The following is a description of a gene set: Genes upregulated in Treg cells from Progressive Idiopathic Pulmonary Fibrosis Patients vs. Stable Non-Progressors from publication Unterman A, Zhao AY, Neumark N, Schupp JC, Ahangari F, Cosme C Jr, Sharma P, Flint J, Stein Y, Ryu C, Ishikawa G, Sumida TS, Gomez JL, Herazo-Maya JD, Dela Cruz CS, Herzog EL, Kaminski N (PMID 38717443) species: Homo sapiens Thirty-eight PBMC samples from 25 patients with IPF and 13 matched controls yielded 149,564 cells that segregated into 23 subpopulations. Classical monocytes were increased in progressive and stable IPF compared to controls (32.1%, 25.2%, 17.9%, respectively, p<0.05). Total lymphocytes were decreased in IPF vs controls, and in progressive vs stable IPF (52.6% vs 62.6%, p=0.035). Tregs were increased in progressive vs stable IPF (1.8% vs 1.1% of all PBMC, p=0.007), although not different than controls, and may be associated with decreased survival (P=0.009 in Kaplan-Meier analysis; P=0.069 after adjusting for age, sex, and baseline FVC). Flow cytometry analysis confirmed this finding in an independent cohort of IPF patients. Fraction of Tregs out of all T cells was also increased in two cohorts of lung scRNA-seq. CCL22 and CCL18, ligands for CCR4 and CCR8 Treg chemotaxis receptors, were increased in IPF. The single-cell atlas of the peripheral immune system in IPF, reveals an outcome-predictive increase in classical monocytes and Tregs, as well as evidence for a lung-blood immune recruitment axis involving CCL7 (for classical monocytes) and CCL18/CCL22 (for Tregs). (From Abstract) Human Gene Set: UNTERMAN_IPF_VS_CTRL_TREG_CELL_UP, and this is the list of marker genes: SIT1, GIMAP4, PIM1, S1PR4, CORO1B (NCBI Gene Id 57175), TIGIT, RPS20, TAP1, PIM2, MT-ATP8, GIMAP7, TNFRSF1B, CISH, S100A11, VIM